Given this list of marker genes Mkx, Cbx8, Tmem131, Eng, Acvr1b, Ucn, Gli2, Serpine1, Col5a1, Ccn2, Suco, Ddr2, Rapgef3, Itga2 (NCBI Gene Id 16398), Prdx5, P3h3, Vim, Tgfb3, Pdgfrb, Adora2b, Nr1h4, Ep300, Emilin1, Larp6, Ager, Tgfb1, Got1, Cygb, Tram2, Uts2, F2r, Col1a1, P3h4, Cyp2j6, Serpinh1, Notch1, Ccl2 (C-C motif chemokine ligand 2), Serpinf2, Ltbp1, Arrb2, Il6ra (NCBI Gene Id 16194), Adamts3 (NCBI Gene Id 68426), Myb, Ppard, Scx, Errfi1 (ERBB receptor feedback inhibitor 1), Il6, Fn1, Nppc, Pdgfb, Fosl2, Bmp4, F2, Il18, Arg1, Ihh, Rap1a, Inhba, Creb3l1, Cyp7a1, Serpinb7, Pparg, Wnt4, Rgcc, Rcn3, Dicer1, here is a description of the gene set: studied in species Mus musculus The chemical reactions and pathways resulting in the formation of collagen, any of a group of fibrous proteins of very high tensile strength that form the main component of connective tissue in animals. Collagen is highly enriched in glycine (some regions are 33% glycine) and proline, occurring predominantly as 3-hydroxyproline (about 20%). Mouse Gene Set: GOBP_COLLAGEN_BIOSYNTHETIC_PROCESS